The following is a description of a gene set: Mouse Gene Set: MIR_3552 studied in species Mus musculus Genes predicted to be targets of miRBase v22 microRNA mmu_miR_3552 in miRDB v6.0 with MirTarget v4 prediction scores > 80 (high confidence targets). from publication Chen Y, Wang X (PMID 31504780), and this is the list of marker genes: Hapstr1, Jph3, Sowaha, Car13, Stra6, Zfp160, Esrrg, Gnal, Adcyap1r1, Habp2, Cbll1, Csde1, Arnt, Psg29, Sftpa1, Smurf2, Larp1, Syt15, Ubr3, Tor1aip2, Cdk19, Car10, Foxo1, Itch (itchy, E3 ubiquitin protein ligase), Eif4a2, Arhgap21, Stox2, Atg13, Trpm1, Ppp1r14d, Defb20, Vapb, Arid2, Sema3e, Mier1, Gata3, Kpna4, Plxna2, Wasf2, Igsf10, Yipf3, Clasp2, Mllt1, Oxct1, Secisbp2l, Faim2, Samd4, R3hdm1, Gabrb2, Zfand3, Surf4, Sucla2, Uhmk1, Chd1, Inafm2, Abr, Syndig1l, Atrn, Sspo, Adamts17, Cyrib, 1700030J22Rik, Ildr2, Sh3gl3, Iqce, Tmcc2, Nkain2, Cdc42ep3, Cdc42ep4, Gtdc1, Vwa2